The following is a description of a gene set: Human Gene Set: REACTOME_FGFR3_LIGAND_BINDING_AND_ACTIVATION FGFR3 ligand binding and activation studied in species Homo sapiens, and this is the list of marker genes: FGF4, FGF16, FGF23, FGF1, FGF5, FGF17, FGF9, FGF8, FGF20, GALNT3, FGF2, FGF18 (fibroblast growth factor 18), FGFR3